Given this list of marker genes LDB3, ANKRD1, MYH11, PDGFRA, SYNPO2L, MYBPC1, MYOZ1, ACTC1, ADPRHL1, MYPN, CFL2, SIX4, LMOD3, TNNT2, CSRP3, FHOD3, MYOM3, KLHL41, TNNT1, FLII, TCAP, LMOD1, MYOM2, TMOD3, TMOD4, SMAD4, ACTG1, NKX2-5, LMOD2, WDR1, MYOM1, ITGB1, ACTA1, NRAP, MYBPH, PLEC, CASQ1, TTN, CAV3, OBSL1 (NCBI Gene Id 731094), ACTN2, PRKD1, SRF, TMOD1, PRKAR1A, MYL9, FLNC, NEBL, EDN1, MEF2A, MYBPC2, AKAP13, OBSCN, MYBPC3, MYH6, NEB, KRT19, CFLAR, TNNT3, BMP10, MYOZ2, MYH10, MIR1-1, PGM5, CSRP2, PDGFRB, MYH3, CSRP1, TPM1, MYLK3, TMOD2, PROX1, MYL2, CAPN3, ANKRD23, here is a description of the gene set: Formation of myofibrils, the repeating units of striated muscle. Human Gene Set: GOBP_MYOFIBRIL_ASSEMBLY studied in species Homo sapiens